Given this list of marker genes Efemp2, Mylk, Col3a1, Mir145a, Prox1, Mir143, here is a description of the gene set: Mouse Gene Set: GOBP_AORTA_SMOOTH_MUSCLE_TISSUE_MORPHOGENESIS species: Mus musculus The process in which the structure of the smooth muscle tissue surrounding the aorta is generated and organized. An aorta is an artery that carries blood from the heart to other parts of the body.